The following is a description of a gene set: Human Gene Set: GSE3982_BCELL_VS_CENT_MEMORY_CD4_TCELL_DN from publication Jeffrey KL, Brummer T, Rolph MS, Liu SM, Callejas NA, Grumont RJ, Gillieron C, Mackay F, Grey S, Camps M, Rommel C, Gerondakis SD, Mackay CR (PMID 16474395) In the present study we used Affymetrix oligonucleotide microarrays to produce gene transcription profiles for the major leukocyte types in humans. This comprehensive dataset enabled us to not only establish which genes were expressed in each leukocyte type, but also which genes were expressed in each subset after activation. The used of a comprehensive dataset of gene profiles from all the major human leukocyte subsets enabled a novel and powerful means for identification of genes associated with single leukocyte subsets, or different immune paradigms. Genes down-regulated in comparison of B cells versus central memory CD4 T cells. species: Homo sapiens, and this is the list of marker genes: GABRA3, FAM174B, SERPINA6, SPATA6L (NCBI Gene Id 55064), CHRNB3, LUZP4, PDIA2, PRL, FCF1, CHN1, ETV3, HOXA4, AGR2 (anterior gradient 2, protein disulphide isomerase family member), FGFBP1, CCL13, PCDHB11, NRXN1, FKBP5, HTT, CD28, OR11A1, SYNM, COL10A1, RASGRF1, CAPN9, ADNP2, HOXB2, M6PR, TSPAN2, CREBL2, TCF7, PLK3, CSPG4, LCK, TMPRSS3, CSTPP1, GRAP2 (GRB2 related adaptor protein 2), KIT, PRR5L, GPA33, KIF21B, CYBRD1, POLD3, PSORS1C1, ATP10A, DLX6, ZNF12, PON3, GPR37L1, HOXB8, NPR2, MEOX2, RUNDC3A, TPSG1, AKR1C1, IL18RAP, GRM5, TNFRSF12A, CCDC170 (NCBI Gene Id 80129), AUTS2, GABARAPL1, SATB1, COLEC11, ZDHHC18, OR2B2, LGALS3BP, CASP6, NXN, SLC22A1, CXCL11, MEOX1, TSPAN6, PXN (paxillin), MLLT3, TPM2, SLC12A7, PRKAA2, CACNB1, SEMA4C, DAZAP2, H4C7, RPL5, MTSS2, PLXDC1, HAND2, MT1F, NPHS1, ITGA2, ADGRE1, PHOX2A, ING3, LRRFIP1, ITGA9, MMP15, NDNF, CD177, CAMSAP2, FOXL1, RRM1, SMIM7, WHRN, MANSC1, DENND1B, HAUS7, DPP4, IL11, FKBP10, CLEC4M, MTRF1L, POGLUT1, NR4A3 (NCBI Gene Id 8013), MLLT1, DNAH7, PCNX2, RASAL2, ZAP70, SLC2A4, SORBS3, SLC28A2, TXK, CDH9, SASH1, MPHOSPH8, PCLO, ADTRP, KMT2A, SBNO1, C1orf216, PTPN13, COL11A1, CCDC177, NAP1L4, MAG, HBE1, RUSC1, SEPTIN9, FAM168A, AP1M2, GLRA3, SAMHD1, TTC22, ASTN1, MRC2, GAS1, MVB12B, PHLDA1, ACKR3, ZNF467 (NCBI Gene Id 168544), ADCY10, CDH8, E2F3, KLHL3, TSPAN15, SDC4 (syndecan 4), DCHS1, EVC, RUNX1, TNS1, IL7R, LDHB, AVPR1A, MID2 (midline 2), PCYOX1L, NECTIN3, FBXO22, CETP, DKFZP434A062, MBP, HNRNPA1, USP10, OBP2A, TLK2, DDR1-DT, MICAL2, BOK, KRT32, C1S (NCBI Gene Id 716), SLC14A1, EXOC6B, TTLL3, PATJ, EFHC2, TEX28, KLHL23, FCN3, DPF1, P2RY1, MSR1, ACSL6, DLC1, EEF1AKMT3, TLR3, MBL2, CCL5, ZNF34, KIF1B, TSBP1, H3C12